The following is a description of a gene set: from publication Mages J, Dietrich H, Lang R (PMID 18086374) Human Gene Set: GSE8621_LPS_STIM_VS_LPS_PRIMED_AND_LPS_STIM_MACROPHAGE_DN Genes down-regulated in macrophages in response to LPS: naïve versus tolerant. Among the multiple mechanisms that control the intensity and duration of macrophage activation, the development of a state of refractoriness to a second stimulation in cells treated with LPS has long been recognized. Release of inhibitory cytokines and alterations in intracellular signaling pathways may be involved in the development of LPS tolerance. Although a number of molecules have been implicated, a detailed picture of the molecular changes in LPS tolerance is still missing. We have used a genome-wide gene expression analysis approach to (i) define which fraction of LPS target genes are subject to tolerance induction and (ii) identify genes that are expressed at high levels in tolerant macrophages. Our data show that in LPS tolerant macrophages the vast majority of LPS-induced gene expression is abrogated. The extent of tolerance induction varies for individual genes, and a small subset appears to be excepted. Compared to other negative control mechanisms of macrophages, e.g. IL-10-induced deactivation, LPS-tolerance inhibits a much wider range of transcriptional targets. Some previously described negative regulators of TLR-signaling (e.g. IRAK-M) were confirmed as expressed at higher levels in LPS-tolerant macrophages. In addition, we discuss other potential players in LPS tolerance identified in this group of genes. studied in species Homo sapiens, and this is the list of marker genes: SNRK, CENPH, TTC13, HSF4, WASHC4, GLB1, GPCPD1, RPS6, CABCOCO1, CYBC1, CD44, EEF1G, LDLRAD4, BAIAP2, HDAC9, SPATA24, MEOX2, TICRR, ACADL, TTC38, PPP3CC, CCNB2, SNN, HEXB, TRIO, PIK3R5, PURG, POLD3, OXGR1, SH2D5, KBTBD11, DHRS3, NMI, PIGA, MAK16 (MAK16 homolog), CHL1, LIN9, NUP43, CAMK1D, IKZF1, GAB3, AIMP1, GSK3B, CENPP, RAPGEF3, IPCEF1, PRMT5, WDFY1, EMB (embigin), PGLYRP1, LIMD2, TMEM186, PYROXD1, LHX8, GPR65, VSIR, RFWD3, LCP1, CXCL6, ADH5 (alcohol dehydrogenase 5 (class III), chi polypeptide), ACSL4, CSNK2A2, ARL14, B3GNT5, SAMSN1, TULP4 (NCBI Gene Id 56995), EPB41L3, TFRC, SLC43A2, LRRC75A, SEMA3D, SMG7, TMX2, LRP1, OSMR, DPY30, IMPA2, CHGA, AKNA (NCBI Gene Id 80709), MPEG1, BRD3, TRPS1, CCSER1, UBE2V2, LCK (NCBI Gene Id 95387), PARP8, RCSD1, MBNL2, RAD18, FOXP1, SHMT2, FAM111A, GBE1 (1,4-alpha-glucan branching enzyme 1), MLLT6 (MLLT6, PHD finger containing), KPNA4, ZNHIT1, LPCAT2 (lysophosphatidylcholine acyltransferase 2), MAP3K1, NAA15, STARD3, PDE7A, MYO1F, FRMD6, MTHFS, RNF168, MIA2, DUSP7, DHRS1, ANO10, FAM234A (NCBI Gene Id 83986), TMEM43, EIF2S1, EIF3G, EVI5, HAO1, C19orf12, CD33 (NCBI Gene Id 945), SKIC8, WIPF1, ESR1, TIMELESS, TLR7, ABHD17B, DPCD, ATP8B4, VPS26C, NDUFS2, ARMC1 (NCBI Gene Id 55156), ASPM, ETS1, REPS1, MFSD2A, IL12A, CD86, TCF19, DNAJC9, RILPL2, SULT6B1, PFDN5, SHPK, SLC29A1 (solute carrier family 29 member 1 (Augustine blood group)), SGPL1, TREX1, CD82 (CD82 molecule), MCM8, IFT81, UBLCP1, POC1B, EED, KICS2, ABI3, ORAI1, DYNLL1, SAP30, WDR26, EBPL, ZSCAN21, B3GALNT1, SRBD1, HLA-DMB, NFKBIE, FBXW4, RNF141, DOCK10, PPP2R5D, PGLS, TBX3, FAM170A, LRBA, KCTD12, MTM1, ARHGEF26 (Rho guanine nucleotide exchange factor 26), TEDC1, HLA-DOB, TRIP12, MAP3K4, METTL14, RNF150, EPSTI1, PRTG, NUDT17, LRRC40, CRIP3, GALNT14 (polypeptide N-acetylgalactosaminyltransferase 14), ICOS, SLC26A3, PPP4R2, GNA13, OSBPL11, CDS1, CHORDC1, DHX29, IRF8, NHERF1, BPNT2, KIZ, MMP2, LITAF (NCBI Gene Id 9516), DIMT1, PAFAH1B3